The following is a description of a gene set: Mouse Gene Set: GOBP_REGULATION_OF_INTRACELLULAR_MRNA_LOCALIZATION Any process that modulates the frequency, rate or extent of intracellular mRNA localization. studied in species Mus musculus, and this is the list of marker genes: Pum2, Hnrnpab, Htt (huntingtin), Zfp36, Zfp36l1, Dhx36 (DEAH-box helicase 36)